Given this list of marker genes SLC36A2, here is a description of the gene set: part of: SLC transporter disorders Reactome Pathway: Defective SLC36A2 causes iminoglycinuria (IG) and hyperglycinuria (HG) SLC36A2 encodes proton-coupled amino acid transporter 2 (PAT2), a high-affinity cotransporter of glycine and proline coupled with the uptake of a proton in kidney and muscles (Schweikhard & Ziegler 2012). Defects in SLC36A2 can cause iminoglycinuria (IG; MIM:242600), an autosomal recessive abnormality of renal transport of glycine and the imino acids proline and hydroxyproline. Defects can also cause hyperglycinuria (HG; MIM:138500), a related disorder to IG which is characterised by excess glycine in the urine. Polymorphisms in the modifiers SLC6A18, 19 and 20, contribute to these phenotypes. species: Homo sapiens